Given this list of marker genes GZMA, PPBP, STRADB, DNASE1, SMARCA2, BFAR (bifunctional apoptosis regulator), here is a description of the gene set: To obtain insight into the physiological functions of the Krüppel-like zinc finger protein Gli-similar 2 (Glis2), mice deficient in Glis2 expression were generated. Glis2 mutant (Glis2(mut)) mice exhibit significantly shorter life spans than do littermate wild-type (WT) mice due to the development of progressive chronic kidney disease with features resembling nephronophthisis. Glis2(mut) mice develop severe renal atrophy involving increased cell death and basement membrane thickening in the proximal convoluted tubules. This development is accompanied by infiltration of lymphocytic inflammatory cells and interstitial/glomerular fibrosis. The severity of the fibrosis, inflammatory infiltrates, and glomerular and tubular changes progresses with age. Blood urea nitrogen and creatinine increase, and Glis2(mut) mice develop proteinuria and ultimately die prematurely of renal failure. A comparison of the gene expression profiles of kidneys from 25-day-old/60-day-old WT and Glis2(mut) mice by microarray analysis showed increased expressions of many genes involved in immune responses/inflammation and fibrosis/tissue remodeling in kidneys of Glis2(mut) mice, including several cytokines and adhesion and extracellular matrix proteins. Our data demonstrate that a deficiency in Glis2 expression leads to tubular atrophy and progressive fibrosis, similar to nephronophthisis, that ultimately results in renal failure. Our study indicates that Glis2 plays a critical role in the maintenance of normal kidney architecture and functions. from publication Kim YS, Kang HS, Herbert R, Beak JY, Collins JB, Grissom SF, Jetten AM (PMID 18227149) Human Gene Set: KIM_GLIS2_TARGETS_DN Partial list of genes down-regulated in the kidney of GLIS2 knockout mice compared to the wild type. studied in species Mus musculus